Given this list of marker genes BBS2, NUF2, FANCD2, CNOT10, CHAF1A, RSRC2, USP6NL, TUBD1, NCS1, BUB1B, CCNF, EFHC1, POM121, ZBED5 (NCBI Gene Id 58486), FBXL20, SHCBP1 (NCBI Gene Id 79801), RMI1, CDC25C, JMJD1C, CREBZF, CCNA2, MCM4, SRF, FRZB, UBL3, GCSH, ITGB3, ENTREP3, VPS72, CDC6, CDKN2C, CKS1B (NCBI Gene Id 88475), KDM5B, AHI1, NPAT, ELP3, H4C14, TAB2 (TGF-beta activated kinase 1 (MAP3K7) binding protein 2), FXR1, STAT5B, TSG101, ORC3, IDO1, GRK6 (G protein-coupled receptor kinase 6), CDH24, TLE3, GOLGA8A, CAPN7, FAM83D, ZNFX1, TULP4, SEPHS1, SS18, WDR62, INSIG2, NSUN3, CDC25A, RPS25, MDM1, UBR7, RBBP8, USP1, TNPO2, HMGB2, ZC3HC1, SH3GL2 (NCBI Gene Id 6456), IDI2, FAM110A, PLK2, VEGFC, KPNB1, VPS37C, IL18BP, SNUPN, ACD, CKAP2, TIPIN, RAD51, MND1, NUP160, RAD51AP1, MID1, ASIP, DLGAP5, GTSE1, INPP5K, USP53, CENPQ, KRAS, OSBPL6, ZCCHC10, RECQL4, CCNB1, TOP1, DSP, ZNF521, YWHAH, BMP2, NUDT13 (NCBI Gene Id 51055), FAN1, KIF14, CTR9, SPDL1, AURKA, MTCL1, FABP1, CDC27, TTF2, ARGLU1, MASTL, PBK, PCF11, COL7A1, FZR1, MAPK13, RPL27A, ZNF587, HMGB3, TXNDC9, ASXL1, ASPHD2, GAS6, KIAA1586, USP16, NEIL3, RFC2, KAT2B, OTULINL, NUSAP1, CTCF, CPLANE1 (NCBI Gene Id 84157), SPAG5, CDK7, DHFR, RRM2 (NCBI Gene Id 6241), GATA2, CDKN2AIP, CSGALNACT1, NCAPD3 (non-SMC condensin II complex subunit D3), HJURP, SMC4, LMNB1, BIVM, CDC42EP4, SFPQ, CFLAR, FANCG, ANP32E, TROAP, PCED1A, ZRANB2, TUBB4B, RPL13A, NCAPH, GRPEL1, CDR2, A2M, NDE1 (nudE neurodevelopment protein 1), DNAJB6, DNAJC3, KCTD9, UNG, SLC25A36, EXO1, LENG8, NMB, SGK1, DHX8, TRA2A, DONSON, KATNA1, LBR (NCBI Gene Id 653311), PDXP, HCP5, PPP1R2, RANGAP1, CKS2, CYB5R2, NEK2, FOXK2, NAB1, BTBD3, STAG3L1, ANTXR1, UBE2S, NR3C1, PYM1, CIT, GDF15, RHNO1, FANCI, H2AC6, CEP55, CTNND1 (catenin delta 1), CSH2, CLSPN, DZIP3, PRR16, RAB3A, PANK2 (NCBI Gene Id 80025), SEC62, RNPC3, RNF126, VANGL1, PIF1, FYN, SLC4A1AP, CENPL (NCBI Gene Id 91687), KIF20B, CDC7, H2BC4, GOT1, GADD45A, ZNF593 (NCBI Gene Id 51042), AGPAT3, GCLM, CDC20, ZPBP, TMEM138 (transmembrane protein 138), HELLS, DR1, LMNA, PPP1R10, MYCBP2, DNA2, MAGT1, E2F1 (NCBI Gene Id 1869), CKAP5, KATNBL1, CBX3, HOXB4, RGS3, SERPINB3, PAK1IP1, KIAA0586, CDCA7L, CCNE1, RNF113A, ABCC2, DYNLL1 (NCBI Gene Id 8655), KDM4A, CYTH3, ITPR1, BARD1, MDM2 (NCBI Gene Id 84825), BIRC5, CHML, E2F8, PLCXD1, AFAP1 (NCBI Gene Id 60312), MAP3K2, CDC42EP1, MCM5, MKI67, ILF2, BUD23, HLA-DOA, E2F5, TOMM70, ORMDL1, DET1, MUC1, PSMD11, DIS3, ORC1, NCAPD2, ITPR3, DNAJB1, ASF1B, CDCA7, STAG3, LRRC17, NASP, POGLUT2, MBD4, ATL2, CDK20, CYTH2, VPS25, POC1A, RCCD1, RHEB, DNAJB4, ARHGDIB, DNAJB9, ADH4, MET, MNT, NUP43, GPSM2, GAS1, TACC3, CNIH4, H2AC25 (H2A clustered histone 25), TUBA3C (NCBI Gene Id 7278), NDC80, TMEM132A, CENPF, MGAT2, KIF5B, CCDC90B, SLC44A2, RAD51C, JADE2, MORF4L2, AGFG1, SAP30, TOPBP1, STAG1, SLC22A3, C6, DMXL2, TFAP2A, ROCK1, NFIC, USB1, PTTG1, ZNF414, INSR, FANCA, HSD17B11, PNN, GON7, HSPA8, SLC17A2, SMARCD1, AFDN, RPA2, AP3D1, CDKN3, HIF1A, MCM2, TFF3, ADAMTS1, BIRC2, ABHD10, PRPSAP1, PDGFA, ZSCAN5A, GNB1, MNX1, HSPA1L, PRIM1, MZF1, TXNRD1, IVNS1ABP, TOB2, CHEK2, PKNOX1, H4C2, GMNN, CCNB2, KIF2C, MED31, CTSD, HSPB8, HRAS, ARMC1, SRSF3, NLRP2, BAG3, TMPO, CCDC14, GSE1, BAIAP2, G3BP1, CDKN1B, DNAJC6, BUB1, HORMAD1, KIF23, RFC4, KPNA2, CADM1, RUNX1, MSH2, SLC25A27, CDC16, GINS3, INSM1 (INSM transcriptional repressor 1), JPT1, SHTN1, SRSF10, PIMREG, TRIP13, DEPDC1B, TRMT2A, IFIT1, PRR11, PSEN1, PRC1, ATF7IP, TOMM34, APEX2, ANKRD10, KBTBD2, ARHGAP8, HERPUD2, CENPE, HAUS5, RHOBTB3, CENPU, MRPL19, VCAM1, C4B, RAD18 (RAD18 E3 ubiquitin protein ligase), SRSF7, NKTR, EBI3, CFD, KCTD2, CCNE2, ADGRG6, PTMS, CDKL5, PLIN3, CDCA3, AP3M2, MRPS2, DMTF1, AURKB, TGIF1 (TGFB induced factor homeobox 1), CIP2A, KLF9, THRAP3, A1BG, VCL, PRKAR1A, COQ6, CRK, PPP2CA (NCBI Gene Id 5515), TSKU, SMTN, SV2B, CAPS, AKIRIN2, CENPA, CYP4F29P, LARP1, ATAD2, RNPS1, TOP3A, PPP3CA, UBE2T, LYAR, KIF11, UBE2D3, H4C3, BRD8, CDC45, PSMG3, MAD2L1, SLC38A2 (NCBI Gene Id 95454), H2AX, POLQ, TTC38, CCND1, MITF, LARP7, PCLAF (PCNA clamp associated factor), HP1BP3 (heterochromatin protein 1 binding protein 3), CDKN2D, MELK, ARHGEF39, HDAC3, SLBP, MIS18BP1, PTP4A1, CDC25B, MAN1A2 (NCBI Gene Id 10905), OLR1 (oxidized low density lipoprotein receptor 1), ADCY6, LINC00339, ZWINT, QRICH1, AKAP13, DTL, ARHGAP19, RIDA (reactive intermediate imine deaminase A homolog), ADGRE5, NCOA5 (nuclear receptor coactivator 5), ZNF281, CXCL14, HMMR, CDC42, HAUS8, ABCA7, H4C5, ME3, TRAIP, SINHCAF, HSF2, POLA1, STAT1, CEP44, FKBP1A, ODF2, TIMP1, HMGCR, DENND11, WSB1, PKMYT1, H4C8 (NCBI Gene Id 8365), NUP37 (nucleoporin 37), SRD5A1, KMO, PLK1, INTS7 (integrator complex subunit 7), ATOSA, NBPF14, OSGIN2, MAP2K6, ACAP3, ARHGAP11A, NCOA3, MEGF9, KMT5B (lysine methyltransferase 5B), MEPCE, H1-0, BCLAF1, UBE2C, TUBB2A, KNSTRN (kinetochore localized astrin (SPAG5) binding protein), BORA, CASP3, NUP98, PCNA (proliferating cell nuclear antigen), MRI1, FADD, RERE, TTC31, LRIF1, USP13, NNMT, ZBTB7A, PASK, DKC1, OGT, CASP8AP2, LMO4, TPX2, SLF2, ENOSF1 (enolase superfamily member 1), CEP70, CRYBA1, NFE2L2, RRP1, MRPS18B, AOC2, TSN, MCM6, TOP2A, UACA (uveal autoantigen with coiled-coil domains and ankyrin repeats), SHC1, NFIA, DDX11, CWC15, TSC22D1, NUDT4, PPP6R3, SAP30BP, ACYP1, DCAF7, G2E3, BRCA1, CHAF1B, POLD3, SMARCB1, SYNCRIP, KLF6, RAN, ZNHIT2, RAB23, ZMYM1, ZNF207, DSCC1, PTPN9, KMT5AP1, CNN2, SDC1, HPS4, ERN2, BUB3, UBQLN2, TRIM45, NUCKS1, ARL4A, TYMS, HSPA13, ANP32B, OSER1, RRM1, EIF4E, PWP1, CDCA8, CIC, LPP (LIM domain containing preferred translocation partner in lipoma), KIF22, CENPM, DCTN6, CD24, SRSF5, DUSP4, AOC3, ARL6IP1, MCAM, GINS2, MDC1, KIFC1, H2AC17, DCAF16, HMG20B, FEM1B, DEXI, HLA-DRA, STIL, RAD54L, AP4B1, ECT2, PRIM2, SSR3, BRD7, UHRF1, REEP1, FLAD1, TUBA1A, RAD21, PIK3CD, ANLN, H2BC21, SUCLG2, NT5DC1, RBM8A, RCAN1, FOXM1, SELENON, ESPL1, PATJ, MATN2, SLC39A10, AMD1, MCM8, TTK, FEN1, VTA1, KANK2, ZNF217, NIPBL, here is a description of the gene set: Human Gene Set: BENPORATH_CYCLING_GENES Cancer cells possess traits reminiscent of those ascribed to normal stem cells. It is unclear, however, whether these phenotypic similarities reflect the activity of common molecular pathways. Here, we analyze the enrichment patterns of gene sets associated with embryonic stem (ES) cell identity in the expression profiles of various human tumor types. We find that histologically poorly differentiated tumors show preferential overexpression of genes normally enriched in ES cells, combined with preferential repression of Polycomb-regulated genes. Moreover, activation targets of Nanog, Oct4, Sox2 and c-Myc are more frequently overexpressed in poorly differentiated tumors than in well-differentiated tumors. In breast cancers, this ES-like signature is associated with high-grade estrogen receptor (ER)-negative tumors, often of the basal-like subtype, and with poor clinical outcome. The ES signature is also present in poorly differentiated glioblastomas and bladder carcinomas. We identify a subset of ES cell-associated transcription regulators that are highly expressed in poorly differentiated tumors. Our results reveal a previously unknown link between genes associated with ES cell identity and the histopathological traits of tumors and support the possibility that these genes contribute to stem cell-like phenotypes shown by many tumors. studied in species Homo sapiens from publication Ben-Porath I, Thomson MW, Carey VJ, Ge R, Bell GW, Regev A, Weinberg RA (PMID 18443585) Genes showing cell-cycle stage-specific expression.